The following is a description of a gene set: Human Gene Set: HERNANDEZ_MITOTIC_ARREST_BY_DOCETAXEL_1_DN Genes down-regulated in MCF7 cells (breast cancer, normal TP53) undergoing mitotic arrest and apoptosis after treatment with 100 nM docetaxel. from publication Hernández-Vargas H, Palacios J, Moreno-Bueno G (PMID 17099726) studied in species Homo sapiens Among microtubule-targeting agents, docetaxel has received recent interest owing to its good therapeutic index. Clinical trials have underlined its potential for the treatment of advanced breast cancer, although little is known about its molecular mode of action in this context. We characterized the molecular changes induced by docetaxel in two well-known human breast carcinoma cell lines. Two mechanisms of action according to drug concentration were suggested by a biphasic sensitivity curve, and were further validated by cell morphology, cell cycle and cell death changes. Two to four nanomolar docetaxel induced aberrant mitosis followed by late necrosis, and 100 nM docetaxel induced mitotic arrest followed by apoptosis. Passing through mitosis phase was a requirement for hypodiploidy to occur, as shown by functional studies in synchronized cells and by combining docetaxel with the proteasome inhibitor MG132. Transcriptional profiling showed differences according to cell line and docetaxel concentration, with cell cycle, cell death and structural genes commonly regulated in both cell lines. Although p53 targets were mainly induced with low concentration of drug in MCF7 cells, its relevance in the dual mechanism of docetaxel cytotoxicity was ruled out by using an isogenic shp53 cell line. Many of the genes shown in this study may contribute to the dual mechanism by which docetaxel inhibits the growth of breast cancer cells at different concentrations. These findings provide a basis for rationally enhancing docetaxel therapy, considering lower concentrations, and better drug combinations., and this is the list of marker genes: XIST, LTBP3, PDGFRA, CDH11, RGS2, CTHRC1 (collagen triple helix repeat containing 1), UBE2C, DPYSL2, CKS1B, GLRX, MAN1A1, FIS1, PDGFC, CLEC2B, CDK2, GBE1, DTL, SNAI2, CDK1, H4C3, SLC29A1, SDC2, FHL2, FBXO5, ADGRL2 (adhesion G protein-coupled receptor L2), POLD3, IGFBP1, PMEL, SEMA4C, TUBB, CASP7, CDC6, MAF, CAPG, RASGRF1, KLRK1, PLOD2